The following is a description of a gene set: Any process that stops, prevents or reduces the frequency, rate or extent of vasculature development. Mouse Gene Set: GOBP_NEGATIVE_REGULATION_OF_VASCULATURE_DEVELOPMENT studied in species Mus musculus, and this is the list of marker genes: Dcn, Lif, Sema3e, Gpr4, E2f2, Pf4, Serpinf1, Hoxa5, Ptger4, Sema6a, Stab1, Ptpn6, Crhr2, Fbln5, Atf2, Flt1, Slc12a2, Krit1, Creb3l1, Rock2, Apoh, Adamts9, Abcc8, H2-M3, Minar1, Stat1, Naxe, Hhex, Tie1, Sulf1 (NCBI Gene Id 98668), Angptl7, Cxcr3, Tafa5, Synj2bp, Ago1, Ptn, Ism1, Cd160, Zfp354c, Foxj2, Vash1 (NCBI Gene Id 263410), Col4a3, Angpt2, Fyn, Alox5, Rgcc, Klf2, Col4a2, Sh2b3, Ccn6 (cellular communication network factor 6), Ngfr (nerve growth factor receptor (TNFR superfamily, member 16)), Efna3, Foxc1, Pml, Spry2, Hgs, Ccr2, S2bpcox16, Angpt4, Plg, Pparg (NCBI Gene Id 19016), Shc1, Mir329, Gtf2i, Tnf, Tek, Ptprm, Cnmd, Sparc, Ccl2, Stard13, Adgrb3, Sema4a, Adamts1, Prl7d1, Cd36, Rela, Ngp, Il17f, Sars1, Nf1, Optc, Hhip, Adrb2, Cxcl10, Foxo4, Spred1, Dab2ip, Gadd45a, Ctnnb1, Amot, Agt, Yjefn3, Epn2, Klf4, Thbs4, Plk2, Pik3cb, Pgk1, Hrg, Mecp2, Emilin1, Cd59a, Adgrb2, Tgfb2, Atp2b4, Epha2, Adgrb1, Pde3b, Qki, Tnmd, Wnt4, Ecscr, Thbs1, Cldn5, Thbs2 (thrombospondin 2), Serpine1, Epn1, Rock1, Fasl, Tcf4